The following is a description of a gene set: Abnormality of lower limb joint species: Homo sapiens Human Gene Set: HP_ABNORMALITY_OF_LOWER_LIMB_JOINT, and this is the list of marker genes: CARS1, ALAD (NCBI Gene Id 210), MYH3, CHAT, APC2, FGD1, GABRD, TPM2, TOR1AIP1, COL2A1, SLC34A3, SDHB, DPYSL5 (dihydropyrimidinase like 5), PWAR1, RAD51C, GFM2, YWHAE, TCTN3, LGI4, TIMM8A, FGFR2, DSTYK, UBE3B, FANCB, LIMK1, TRPV4, PEX16, SLC35A2, COG8, SYT2, ALG14, VPS37D, PRR12, DNAJC30 (DnaJ heat shock protein family (Hsp40) member C30), AARS1, COL9A2, GJB6, ARF1, ZC4H2, MAP2K2, NAA10, SLCO2A1, HOXA11 (NCBI Gene Id 3207), JMJD1C, SHOX, PHLDB1, SCYL2, TNFSF11, ATP6V0A2, ZEB2, SLC4A10, NGLY1, F8, EVC2, PIGY, EXT1, CBS, ATRX, RINT1, TELO2, NANS (NCBI Gene Id 54187), HSPG2, GPHN, VDR, HIRA, CRELD1, STX1B, GPC3, ADAMTS15, EXOC6B, KRT5 (keratin 5), CUL7, SPEG, CLCN3, RYR3, GCSH, WNK3, SLC25A1, RPL13, GNPAT, FANCC, ARID1B, KAT6A, TTN, MBTPS2, VARS1, SNORD116-1, ABCC6, POLRMT, SRD5A3, PRKACA, SMC1A, SV2A, MAN2C1, CLCN7, TBX15, TGFB2, SPART, STIL, SMO, GET4, HERC2, TNNI2 (troponin I2, fast skeletal type), PAM16, GNPTG, ERCC4, CD247, MYL11, ALG2, BRCA1, RPS15A, NOG, SMG9, ENPP1, DYNLT2B, P4HTM, SELENON, FOXH1, YY1, COQ4, KLHL41, CNTNAP1, ERLIN1, BRF1, GABRA1, SLX4, HACD1, FANCE, SMOC1, COL7A1, FILIP1, GBA2, FANCM, SLC39A8, MYH8, CYP2R1, POMT2, ERCC1, EP300, PUS3, FANCD2, GPX4, CCN2, CHRNB1, FKRP, CHSY1 (NCBI Gene Id 22856), KDM6A, TGIF1, MYO18B, PRKACB, MAD2L2, MARS1, CPT2, NRCAM, HS2ST1, PI4KA, COL9A1, ALDH18A1, TUBB3, ADSS1, MAPK8IP3, BAG3, TRAPPC2 (NCBI Gene Id 6399), CYP3A4, HYAL1, PEPD, HDAC8, EMD, FZD2, PAFAH1B1 (NCBI Gene Id 5048), LBR, TCEAL1, FUT8, PSMD12, WDR19, FANCL, SEC24C, GTF2I, IDUA, PSTPIP1, MYOT, LTBP1, PTCH1 (patched 1), GPC6, CLTCL1, RMRP, CREBBP, MATN3, NEDD4L, CRTAP, IL2RB, AP4M1, TNNT3, LYSET, DYNC2H1, SLC18A3, TBX4, HPRT1, TOR1A, AP4S1, CTC1, JAG2, KLC2, INPPL1, USP9X, COL5A2, XRCC2, NDUFAF6, BRCA2, NIPBL, PRKG2, NALCN, EXOSC3, SERPINF1, COL6A2, POLR3A, MAN2B1, TGDS, NPAP1, BMP1, RTN2, MYL2, TGFBR2, PLOD1, KIAA0586, DMD, COMP, GALNS, EVC, EIF2AK3, TNNT1, TGFB1, HK1, HS6ST1, SAMD9L, MACF1, MASP1, B3GALT6, KAT6B, SMAD3 (SMAD family member 3), COL6A3, NKX3-2, ZSWIM6, UNC80, CAPN1, SMAD2, ALG9, FBLN5, FIG4, ATP5F1D, GMNN, CTCF, RAB18, PMP22, SNRPB, NT5C2, METTL27, DPAGT1, IDH2, RAB3GAP2, GABRG2, HNRNPH1, ANKRD55, BMPR1B (NCBI Gene Id 658), GNB2, DHODH, CYP27B1, SLC6A9, COL9A3, LMBRD2, B3GAT3, AFF3, RFC2, NLRP3, ANO10, KMT2D, ANKLE2, SHROOM4, MCOLN1, PPP2R5D, CYP19A1, MCTP2, SYNE1, GTF2IRD1, BPTF, SCO2, COLEC10, DAG1, UCHL1, PNPT1, COL3A1 (collagen type III alpha 1 chain), TRIM8, ARVCF, MEGF8, FN1, KPNA3, SALL1, NAA60, VAMP1, GDF5, FGFRL1, COLEC11, EFL1, IL6ST, CCN6, NFIX, DNMT3A, ACTA1, UGP2 (NCBI Gene Id 7360), DDR2, DVL1, MMP9 (NCBI Gene Id 4318), GLRB, TMEM67, ORC6, RPL10, FANCI, ERCC8, DYSF, LIFR, EZH2, CTDP1, PITX1, PWRN1, FBLN1, LRP1, WNT5A, ORC1, KLHL9, DYNC2LI1, WASF1, ORAI1, BHLHA9, GLB1, COL5A1, POLR3B, MKRN3, NIPA1, CAMK2A, FBN1, MMP2, RBM8A, PLA2G6, SOD1, MEFV (NCBI Gene Id 4210), MAP3K7 (NCBI Gene Id 6885), MAB21L2, DVL3, PIEZO1, SKI, HACE1, PTRH2, OCA2, COL13A1 (collagen type XIII alpha 1 chain), FHL1, COLQ, ERLIN2, TBL2, COL27A1, CLCN5, GJA1, APC, SELENOI, MTX2, ZIC2, GAN, SLC6A5, AP4E1, IL2RA, SHH, ASAH1, CAPN3, SCN1A, OFD1, ZNF469, BCOR, OSGEP, ERGIC1, SPARC, SATB2, CYP27A1, SFRP4, BICRA, C12orf57, DYRK1A, ERCC6, RPGRIP1L (NCBI Gene Id 23322), SDHD, PIGL, LMX1B, NDUFS8 (NCBI Gene Id 4728), UFD1, BRD4, PCDH19, SLC26A2, CHST3, KIF1A, LAMB2, FANCF, EIF4A3, GLI3, LMOD3, CSPP1, CFL2, ERI1, STAT4, GMPPB, PHEX, XYLT1, ARL6IP1, FGFR1, GUSB, MKKS, TRIM2, B4GALT7 (beta-1,4-galactosyltransferase 7), KIF22, RAD51 (RAD51 recombinase), ZPR1, ZIC3, THRA, STAG2, TONSL, PUF60, ATAD1 (NCBI Gene Id 84896), CANT1 (NCBI Gene Id 619513), PYCR2, BMP4, COL12A1, NTRK1, CTNS (NCBI Gene Id 1497), KIF5A, COL25A1, SH3PXD2B, MMP13, FAT4, CHRNG, PRG4, SIX1, EBF3, AEBP1, IFT56, HDAC4, HPGD, TPM3, CCDC88C, UFC1, AKT1, CPLX1, NSD2, CCDC47, VCP, IFT57, WNT7A (Wnt family member 7A), GNPTAB, MYL1, SPTBN4, FLNB, WDR35, GEMIN4, TTI1, STX1A, KIF1C, GLI2 (GLI family zinc finger 2), C19orf12, VPS33A, CTBP1, SMARCAL1, TRAPPC12, RAB33B, SPG11, DONSON (NCBI Gene Id 55597), ELN, HRAS, OSTM1, ACAN, LARGE1, ARFGEF2, GORAB, RAB23, PIK3CA, UBA2, ERMARD, CD96, ADAMTSL2, GPC4 (glypican 4), KANSL1, OCRL, SF3B2, DMP1, AFF4, CENPJ, RFWD3 (ring finger and WD repeat domain 3), POLR1A, NEPRO, SLC35B2, ZBTB20, DLL1, CENPT, STX5, SMC3, CDC45, MEGF10, MAP1B, GJC2, ATL1, SLC39A14, TMTC3, CEP120, TBC1D7, ANAPC1, DYM, CEP85L, TRPS1, LMNB2, PLAAT3, KIAA0753, SPAST, HGD, COX8A, SLC5A7, SCN1B, ADNP, BICD2, SNORD115-1, FGF9, CBFB, ADGRV1, COG5, PSAT1, IHH, GLRA1, COG1, PTPN22, ASCC3, MAGEL2, PPIB, CD40LG, COL1A1, PALB2, ABCC9, BRIP1, FANCA, NONO, C18orf32, TBCD, DDRGK1, KIF7, ATP6V1E1, GAS1, FKBP10 (FKBP prolyl isomerase 10), FA2H, SLC12A2, STUB1, ATP7A, COL6A1, FANCG, RECQL4, DHCR7 (7-dehydrocholesterol reductase), EXT2, PIK3R2, MAP2K1, ZMPSTE24, CCDC8, IPO8, SIX3, ECEL1, PLOD2, SOX9, STXBP1, CYP7B1, PIGA, SEC31A, IFT52, PIGT, FBN2, TIMM22, FLI1, SLC52A3, ORC4, PYCR1, LAMA5, LMBR1, DNAJC21, HCN1, CDT1, KY, PKDCC, FGFR3, AP4B1, ZNF699, TAF6, IFIH1, RETREG1, CDC6, RTTN, SCN2A, ARSK, AGRN (agrin), COMT, GSC, NODAL, BIN1, DPM1, KRAS, EIF4H, POU3F4, UFSP2, DISP1, SIK3, TBX1, HOXD13, IARS2, COL10A1, SPTBN2, WDR62, RAD21, NF1, UBE3A, ADAMTS2, GLI1, MUSK (NCBI Gene Id 4593), SIL1, CHMP1A, MAFB, NCF1 (neutrophil cytosolic factor 1), SLC10A7, BRAF, PTH1R, HTT, TFE3, UBE2T, BAZ1B, H3-3B, PLCH1, UBR7, NFATC2, SLC2A10, NSDHL, RNU12, RREB1, GALC, FLNC, TRIP11, SCN9A, LONP1, CHD4, RUNX2, ATP6V1A, AP3B1, LMNA (NCBI Gene Id 7816), RNU4ATAC, ATR, MIA3, THOC2, PTDSS1, SCN4A, VPS13B, EBP, COL11A1, CDON, GTF2IRD2, PDGFRB, CLDN16, PRMT7, MFN2, HEATR3, DHX16, PTEN, BUD23, POMT1, EXTL3, OBSL1, GNPNAT1, ADGRG1, VAC14, POR, SLC25A46, PSAP, BPNT2, ZNF407, CRIPTO, MAP3K20, IDH1, EFEMP2, RYR1, IFT172, SERPINH1, SPTBN1, PTPN2, NOTCH2, SDHA, ANO5, PRRT2, SCARF2, CSGALNACT1, ABCD1, GJB2, DYNC2I1, LRP4, COL1A2, SLC16A2, ARSB, SLC35A3, FDFT1, NRAS, SGCA, LETM1, CHST11, COX11, UBA1, ANGPT2, CHRM3, NSD1, ROR2, ESCO2, HNRNPA2B1, TMEM270, FLT4, WNK1, SF3B4, FKBP6, PORCN, GFPT1, PDE4D, CLIP2, GRIA3, AHDC1, FGF8, EYA1, SDHAF1, NFU1, GARS1, FGF13, SLC35D1, AIFM1, TAF4, MPZ, GDF6, HBB, SNAP25, MYO9A, PRKAR1A, ATP6AP2, GP1BB, SLC1A4, PIEZO2, FLNA, REEP1, ARNT2 (NCBI Gene Id 9915), SVIL, TNFRSF1A, NEB, RSPRY1, BGN, ITGA7